Given this list of marker genes B4galnt1, Rbm38, Cbfa2t3, Ppp2r5c, Rpsa, Mapkapk2, Cxcl2, Midn, Ptpn1, Nupr1, Cd8a, Lsp1, Prkcd, Slc27a3, Ctdnep1, Clec4e, Pkm, Hp, Cic, Msn, Socs3, Grb2, Ak2, Dusp3, Scand1, Lrrfip1, Siglech, Arhgdia, Nfkbie, Gnb2, Rnf149, Zfp36, Pglyrp1, Ets2, Ehd1, Cybb, Cyba, Syf2, Bri3, Tppp3, Tkt, Smpdl3b, Cnnm4, Bcl3, Ppp1r18, Lypla2, Sh3bp1 (SH3-domain binding protein 1), Slc2a6, Cebpd, Pnrc1, Cyb5r3, Rpl4, Efhd2, Prr13 (proline rich 13), Spag9, Jund, Rnf19b, Junb, Spi1 (Spi-1 proto-oncogene), Dusp2, Rpl8 (NCBI Gene Id 27051), Rgcc, Rbm3, Tln1, Cxcl1, Tnfaip2, Rilpl2, Cebpb, Cdkn1a, Gngt2, Gadd45b, Kdm6b, Eif5a, Fmnl1, Filip1l, Prdx5, Ier2, Tgif1, Clic4, Crlf2, Csf2ra (colony stimulating factor 2 receptor, alpha, low-affinity (granulocyte-macrophage)), Arhgef1, Nfkbia, Txnrd1, Adgre5, Lmo4, Pfn1, Il1b, Gnb1, Cdc42ep2, Btg1, Rpl13, Pilra, Ccrl2, Ldlr, Sf3b2, Trem1, Apbb1ip, Emc10, Furin, Nadk, Tle5, Dcn, Pakap, Ywhae, Ywhaz, Vmp1, Mospd3, Rpl13a, Actg1, Rplp0, Hcls1, Gpx3, Tex261, Vasp, Rras, Slc16a3, Cotl1 (coactosin like F-actin binding protein 1), Tnfrsf1a, Sparc, Ltb4r1, Mgp, Il10ra, Rack1, Fosl2, Ptpre, Emilin2, Stat3 (signal transducer and activator of transcription 3), Arpc4, Irf1, Lrp1, Eif3f, Ceacam1, Vps37b, Lcn2, Sgk1, Mcemp1, Plaur, Traf1, Id3, Spn, S100a9, Arpc1b, Fn1, Sirpb1c, Treml4, Tmem160, Rhoa (ras homolog family member A), Ndel1, S100a8, Fgr, Gga1, Map3k14, Htra3, Srsf5, Cmip, Hck, Coro1a, Lamtor4, Tgm2, Gpr132, Nr4a1, Tomm6, Pde4b, Pim3, Napsa, Sema4d, Wfdc2, Mbp, Arrb2, Ifrd1, Gsr, Limd2, Cirbp, Arl5c, Sod2, Snrpc (NCBI Gene Id 20630), Drap1, Pi16, Crip2, Ear2, Nfkbiz, Ezr, Gsn, Grk2, Ptprj, Pim1, Stk10, Kpna4, Itgal, Kmt2b, Cfl1, Flna (filamin, alpha), Tmsb10, Ptms, Agpat4, Dusp5, Klf13, Cd9, Bhlhe40, Csrnp1, Arl8a, here is a description of the gene set: from publication Tabula Muris Consortium (PMID 32669714) Mouse Gene Set: TABULA_MURIS_SENIS_SUBCUTANEOUS_ADIPOSE_TISSUE_MYELOID_CELL_AGEING species: Mus musculus